Given this list of marker genes Edrf1, Rab24, Asxl1, Snord45c, Eif3i, Ndufa11, Efcab7, Psmd5, Rps23, Yy1, Tmco1, Wdr6, Mre11a, 4930506C21Rik, Hint1, Inpp5f (NCBI Gene Id 79372, inositol polyphosphate-5-phosphatase F), Atp6v1a, C430014B12Rik, Gm23130, Stam, Smg7, Bckdha, Pop7, Dnajc27, Dnajb9, Taf10, Rxrb, Psph, Gpn3, Tsr3, Eif4enif1, Pih1d2, Asph, Coq9, Cct8, Nsun2, Ptprs, Ankrd24, Mir9-3, Agtpbp1, Arl2bp, Gm9958, Smdt1, Dph3, Arl8a, Ift74, Mettl16, Fam135a, Srp19, Rps2, Rc3h2, Mms22l, Cox11, Mkrn1, Zfand5 (NCBI Gene Id 76103), Tas1r1, Xpo6, Clhc1, Supv3l1, Tspyl1, Prkab2, Ntaq1, Bcas3, Nt5m, 9130604C24Rik, Chmp1a, Rpl30, Hadhb, Dzank1, Lrr1, Tasor2, Faap20, Zkscan8, Ribc2, Zfpl1, Hadha, Stag3, Gtf2h1 (general transcription factor II H, polypeptide 1), Rbbp5, Rps12, Ube2f, Cand1, Ncapg, 2810454H06Rik, Uspl1, Cep41, Pus3, Oxnad1, Zkscan2, Rps6, Myef2, Dync1li2, Ireb2, Snhg9, Rbm39 (RNA binding motif protein 39), 2810402E24Rik, Cox7a2l, Exosc10, Ccdc28a, Sugp1, Rps29, 1700112D23Rik, Mbtps1, Wdr77, Kazald1 (Kazal-type serine peptidase inhibitor domain 1), Irgq, Slc39a7, 1700045H11Rik, 6030442K20Rik, Ube2i, Kif9, Ube2b, Rexo5, Pcmtd1, Tab3, Ccdc62, Ddx27, 6430590A07Rik, Tti1, Blcap, Nol9, Mrps27, Tbck, Gm16576, Tex10 (testis expressed gene 10), Dars1, Mon2, Hs2st1, Zmym3, B130034C11Rik, Snora64, Parg, Eftud2, Anapc7, Prkar1a, Bag4, Lsm1, Rps28, Copb2, Zfc3h1, 4933406P04Rik, Cactin, 3110083C13Rik, Jarid2, Dmap1, Nnat, Pcbd2, Tmem79, Mapkapk5, Gm23301, Cul5, Sh3bp1, Rpp38, Prelid1, Eif2s3x, Zbtb5, Tacc3, Rps7, Rpl27a, Rpl9, Abhd18 (NCBI Gene Id 99688), Yae1d1, 4930579K19Rik, Pafah1b2, Yrdc, Cdk5rap2, Pomp, Spag16, Cip2a, Ccar2, Selenoo, Eif3e, Camk2d, Ercc6l2, Gm20186, Meiosin, Rpl12, Eef1b2, Timm23 (NCBI Gene Id 53915), Thada, Hdhd2 (haloacid dehalogenase-like hydrolase domain containing 2), Hps5, Ska3, Eri2, Itfg2, 2410002F23Rik, Mm2pr, Sec23ip, Nprl3, Nbea, Gm26973, Rps15 (ribosomal protein S15), Etfa, Eif4e2, Bap1, Tnpo3, Atf7, Stxbp4, Gm10244, 5330439K02Rik, Cdc5l, Dis3, Rac1, Gdi2 (NCBI Gene Id 14569), Sf3a3, Taok1, Gm11205, Klf10, Tmem234, Selenof, Psmg2, Ddost, Vcf1, Snord58b, Rpl4, Znhit1, Usf1, Hspa4, Camta1, Dguok, Brd2, Gm16023, Actl6a, Fibp, Uqcrh (NCBI Gene Id 78331), Mau2, Mir5627, Smg5, Mad1l1, Med22, Zfp219, 3000002C10Rik, Eif2s1, Angel1, Zbtb40, Cdk11b, Fam162a, Cwc22, Herpud1, Ube2d2a, Mtnap1, Ift56, Pfdn4, Micu2, Tle1, Naa25, Uhmk1, Mtmr2, Uhrf2, Cct5, Vars1, Emc3, Vdac3, Ddx25, Tkt, Tgs1, Matr3, Cct6a, Gm23969, Idh3g, Gm17484, Rimklb, Atp5mc3, Skp1 (S-phase kinase-associated protein 1), C630043F03Rik (RIKEN cDNA C630043F03 gene), Tex9, Jrk, Klhl22, Tubb4b, Spdl1, Mrpl51, Ggnbp2, Ankfy1, Mrps35, Mtmr9, Sec62, Nmd3, Atp5f1c, Zzz3, Rpl35a, Nkapd1, Rabggtb, Sirt6, 4833439L19Rik, Rpl18, Mrpl57, Stk38l, Ap4e1, Slc39a13, Mfsd8, Zfp787, Polr2e, Ap3m1, Etf1, BC004004, Cdca5, Ccdc96, Ptpn4, Zfp865, B230354K17Rik, Eno4, Aco2, Katna1, Grk4, Eif3l, Sart3, Ncapd2, Mpc2, Pole4, Rpl27, Rad17, Smc2, Plod3, Exosc3, Gm15246, Tmem209, Hmgn1, Mrps18a, Rexo4, Pbld2 (NCBI Gene Id 67307), Rnf4, Dctn1, Ssbp1, Casp7, Trappc2, Slc25a4, Dlx2, Tmed1, Zranb2, Wdr47, Spry1, Gm26670, Ofd1, Atp6v1d, Zfp612, Fam76a, Dedd2, Agbl3, Pcgf1, Ddx20, Fgfr1op2, Gm10827, Zfp938, Ankra2, Pet100, Gas2, Mff, Cnot10, Mrps14, Wdr31, Ndufa4 (Ndufa4, mitochondrial complex associated), Rpl7a, Elmod2, Rprd1b, Klhl18, Taf9, Prpf31, Rpl24 (ribosomal protein L24), Mettl26, Park7, Txndc15, Mob1b (NCBI Gene Id 68473), Mir3077, Zfp422, Zfp655, Mtfr1l, Tm9sf1, Dctn5 (dynactin 5), Palb2, Ndufa10, Ptcd2, Mdh2, Suv39h1, Sf3b2, Ak6, Otud6b, Ttc14, Sae1, Mtif2, Nkrf, Farsb, Alg12, Rps3a1, Ergic2, Sft2d1, Atp5mc1, Ssr1, Denr, Glce, Itgb3bp, Hmgb1, Agl, Ankle2, Cox10, Natd1, Thumpd3, Ssmem1, Phf5a, Sipa1l1, Fbxo22, Vps51, Mir6516, Nr2e1, Cyp51, 1700028E10Rik, Upf2, Ssr4, Vmac, Tfpt, Iws1, Kin, Rdh14, Nfyc, Gm6345, Tut7, Lias, Auts2, Ugp2, Brf1, Trim39, Drg2, Exosc5, Gnptg, Dph6, Bms1, Inafm2, Smad5, 2810001G20Rik, Mob1a, Ankrd17, Ice1, Lrsam1, Ccdc103, Nop14, Suds3, Srsf10, Tpra1, Bcl10, Ap5m1, Nol10, Mdn1, Dipk2a, Vps4b, Nek9, Rraga, Hnrnph3, Fubp1, Slc35b1, Med10, Ndufs1, Banp (NCBI Gene Id 53325), Gm16124 (NCBI Gene Id 102636154), Tnfrsf9, Zfp131, Gpr19, Snrpb, 1700027A07Rik, Tipin, Pes1, Tmem68, Mcm3, Kif2a, Marchf7, Sphk2, Gm14204, Hoxa5, Rbpj, Rpl26, Hps4, Bclaf1, Bud31, A830082K12Rik, Zfp280d, Zfp105, Zfp286, Nvl, Stt3a, Dcaf6, Ecd, Smndc1, Lrrc41, Rpl32, Pfn4, Tmem18, Med18, Qrich1, Ddx31, Gpatch3, Cenpt, Sec63, Golm2, Atp5pb, Ptgr2, Fbxw8, Klhl35, Rpl21, Zcchc14, Aimp1, Srrd, Supt5, Eif5a2, Lsm8, Snora7a, Styxl1, Haspin, Micos10, Noc3l, Slc4a1ap, Myl12a, Fancd2, Nup214, Fam216a, Zfta, 1700055D18Rik, Exoc5, B230219D22Rik, Cep63, Pno1, Dzip3, BC031181, Grb2, Bag1, Npm1, Uvssa, Tubgcp5, Chaf1a, 4930539J05Rik, Icmt, Tsn, Rpl13, 2610037D02Rik, Zfp566, Cnih4, Trappc2b, Snhg16, Ptges3, Fam149b, Mkks, Bzw1, Polr3f, Snora3, Nup85, Hspa9, Ciapin1, Ints13, Utp15, Vdac2, Gm27032, Mir5133, Rnpc3 (NCBI Gene Id 99626), Letmd1, Rpl10a, 1600023N17Rik, Cux2, Mapk14, Rpl17, Abca1, Srcap, Stpg2, Ncoa4, Ppp4r3b, Snx15, Cfap20, Exoc1, Iqcg, Nudt1, Zfp617, Spata33, Mrtfb, Scamp5, Mir124a-3, Ptpdc1, Polr2b, Ubr3, Golga1, Timmdc1, Ing4, Naa50, Fadd, Sox11, Commd3, Ash2l, Septin7, Gorab, Snord3a, Nptn, Ipo13, Eif4a3, Pign, Ehd1, Suclg1, Amdhd2, Rps11, Lamp1, Herc1, Ddhd2, Rab33b, Cep76, Snx1, Baz2b, Tuba1a, Msto1, Ywhab, Noa1, Slx4ip, Pradc1 (NCBI Gene Id 73327), Dus1l, Errfi1, Mboat2, Crim1, Fubp3, Ublcp1, Zwilch, Rps27a, Unc13b, Vti1b, Caprin2, Pim3, 4930592C13Rik, Tmem129, Rab11a, Snhg20, Upf3b, Gm26787, Snora78 (small nucleolar RNA, H/ACA box 7), Snord1c, Naa35, Rnaseh2b, Zfp846, Gm11936, Mkrn3 (makorin, ring finger protein, 3), Fbxw2, Khsrp (KH-type splicing regulatory protein), Luc7l2, Lars2, Phf7, Atpsckmt, Exo5, Atp9b, Puf60, Nktr, Nsun5, Gm27011, Fktn, Pik3ca, Dbr1, Nr3c1, Cdk7, Btbd10, Arf3, Thap2, Zfp568, Man1a2, Relch, Smc1b, Ctdsp1, Dmxl1, Map3k7, Slc12a2, Mcts2, Ndufa7, Psmd12, Stamos, Chuk (NCBI Gene Id 12675), Sun2, Dnaaf10, Slc9a8 (solute carrier family 9 (sodium/hydrogen exchanger), member 8), Khdrbs1, Lsm14a, Prdx1, Rps19, Anapc13, 1110065P20Rik, Xab2, Creld2, Cap1, Klf9, Sap18, Ift80, Tada2b, Rab10os, Smc4, Akap11, Caprin1, Eif5, Supt7l, Snord68, Atox1, Zfp407, Crebzf, Atf2, Fbxo21, Actr3, Adk, Gtf3c4, Ube2d3, Rangap1, 1600012H06Rik, Celsr2, Scrt1, Mak16, Huwe1, Rfesd (NCBI Gene Id 218341), Zbtb38, Dhps, Nat10, Dnajb4, Tcof1, Gm14963, Polr3b, Pgs1, Xpnpep3, Rbm26, Tmem107, Zfp414, Pfkfb2, Rybp, Troap, Tlx2, Srd5a1, Gpc2, Rbm43, Rpl11, Nol11, Cdk12, Psmb2, Hccs, Tcf25, Smarcd2, Nsun3, St13, Stam2, Fscn1, Sf3b1, Nme6, Utp3, Smc2os, Pdap1, Gtf3c6, Gm28047, Phf14, Cd2ap (CD2-associated protein), Iscu, Klhdc2, here is a description of the gene set: Genes containing one or more binding sites for (Fev) in their promoter regions (TSS -1000,+100 bp) as identified by GTRD version 20.06 ChIP-seq harmonization. from publication Yevshin I, Sharipov R, Kolmykov S, Kondrakhin Y, Kolpakov F (PMID 30445619) species: Mus musculus Mouse Gene Set: FEV_TARGET_GENES